Given this list of marker genes Pirb, Adora1, Srf, Sorcs3 (NCBI Gene Id 66673), Vps13a, Ager, Slc24a1, Gria1, Gnal, Kcnb1, Slc24a2, Stxbp1, Mapt (microtubule-associated protein tau), Ptk2b, Drd5, Stau2, Cd38, Pick1, Sorcs2, Pten, Arc, Dgki (NCBI Gene Id 320127), Shank3, Ppp1r9a, Grid2, Plk2, Adcy8, Cbln1, Bcl2l1, Drd1, Penk, Mgll, Grm2, Arf1, Iqsec2, Shank2, Fmr1, Abhd6, Grid2ip, Prrt1 (NCBI Gene Id 27693), here is a description of the gene set: studied in species Mus musculus A process that modulates synaptic plasticity such that synapses are changed resulting in the decrease in the rate, or frequency of synaptic transmission at the synapse. Mouse Gene Set: GOBP_LONG_TERM_SYNAPTIC_DEPRESSION